Given this list of marker genes PLCD4, POM121, INPP1, PLCZ1, TPR, NUP93, NUP42, ITPKB, NUP37, SEH1L, ITPK1, PTEN, NUP88, NUP188, INPP5A, NUP210, SYNJ1, PLCH2, PLCB4, RANBP2, PLCG2, MIOX, NUP62, ITPKA, NUP85, PLD4, NUP133, NUP98, CALM1, SEC13, MTMR9, NUP50, NUP214, IP6K3, NUDT10, IP6K2, NUP58, ITPKC, NUP153, PLCH1, IP6K1, NUDT4, NUP155, NUP107, NUP160, NUDT3, INPP4A, IPPK, INPP5D, IMPA2, NUP205, INPP5B, NDC1, PPIP5K1, MINPP1, PLCB3, PLCE1, INPP5J, PLCD1, PLCD3, IPMK, PLCB2, NUP54, ISYNA1, IMPA1, NUDT11, MTMR7, PLCG1, AAAS, PLCB1, RAE1, POM121C, NUP43, OCRL, PPIP5K2, INPPL1, NUP35, INPP4B, here is a description of the gene set: part of: Metabolism Inositol phosphates (IPs) are molecules involves in signalling processes in eukaryotes. myo-Inositol consists of a six-carbon cyclic alcohol with an axial 2-hydroxy and five equatorial hydroxyls. Mono-, di-, and triphosphorylation of the inositol ring generates a wide variety of stereochemically distinct signalling entities. Inositol 1,4,5-trisphosphate (I(1,4,5)P3), is formed when the phosphoinositide phosphatidylinositol 4,5-bisphosphate (PI(4,5)P2) is hydrolysed by a phospholipase C isozyme. An array of inositol trisphosphate (IP3) and tetrakisphosphate (IP4) molecules are synthesised by the action of various kinases and phosphatases in the cytosol. These species then transport between the cytosol and the nucleus where they are acted on by inositol polyphosphate multikinase (IPMK), inositol-pentakisphosphate 2-kinase (IPPK), inositol hexakisphosphate kinase 1 (IP6K1) and 2 (IP6K2), to produce IP5, IP6, IP7, and IP8 molecules. Some of these nuclear produced IPs transport back to the cytosol where they are converted to an even wider variety of IPs, by kinases and phosphatases, including the di- and triphospho inositol phosphates aka pyrophosphates (Irvine & Schell 2001, Bunney & Katan 2010, Alcazar-Romain & Wente 2008, York 2006, Monserrate and York 2010). Reactome Pathway: Inositol phosphate metabolism species: Homo sapiens